Given this list of marker genes CYGB, RPS6KA1, FAM114A1 (NCBI Gene Id 92689), IL17A, AKAP12, MDM2, RGCC, LEP, ACTA2, GCLM, DDR2, MYB, ULK3, ZEB2, IL17RA, GCLC, here is a description of the gene set: species: Homo sapiens Human Gene Set: GOBP_FIBROBLAST_ACTIVATION A change in the morphology or behavior of a fibroblast resulting from exposure to an activating factor such as a cellular or soluble ligand.